Given this list of marker genes ADGRA3, THBS1 (thrombospondin 1, NCBI Gene Id 7057), ADRB2, PLTP, DNAJB4, TRIB3, HSPA6, JCHAIN, EIF4EBP1, GDF15, SLC3A2, CDS1, PTPRC (protein tyrosine phosphatase receptor type C), MMP16, RCAN2 (regulator of calcineurin 2), PPARGC1A, AAK1, TOX3, HSP90B1, MAF (MAF bZIP transcription factor), RPS6KA2, CTH, DNAJC15, MAFF, RRM2, EPB41L2, CLGN, GOT1, SLC47A1, PPP1R15A, HSPA1B, IDH1, TPP1, CRELD2, RGS16, ENPP2, FAM149A, NIBAN1, IFRD1, DNAJB1, LAPTM5, ATF3, HGF, HBB, BAG3, CBS, SHMT2, PPFIBP1, SLC6A15, CEBPB, E2F2, RFPL2 (ret finger protein like 2), P2RX5, MARS1, MYC, RPS19, PLEKHA8P1, CA2, USH2A (NCBI Gene Id 7399), CCPG1, MZF1, DNAJB9, OSGIN1, AMY1A (amylase alpha 1A), NEAT1, CEACAM1 (NCBI Gene Id 634), SERPINH1, CLK1, SLC5A3 (NCBI Gene Id 6526), SLCO4C1, MIA2, PSAT1, ATF4, OLR1, WARS1, CRBN, ADCYAP1, TXNDC5, DDIT4, SEC24D, CHAC1, UFM1, PKD1, INHBE, DDIT3, SLC1A4, HBG1, ASNS, STK39, PHGDH, MAP1B, F2RL1, SYT11, SLC7A11, HMOX1, HSPA1A, TIMM44, DDAH1, TSHR, CATSPER2, TNFRSF17 (NCBI Gene Id 608), HSPH1, LSAMP, PGM3, HSPA13, LRP2BP, PLG, here is a description of the gene set: studied in species Homo sapiens Genes down-regulated in at least one of three multiple myeloma (MM) cell lines treated with the DNA hypomethylating agent decitabine (5-aza-2'-deoxycytidine). from publication Heller G, Schmidt WM, Ziegler B, Holzer S, Müllauer L, Bilban M, Zielinski CC, Drach J, Zöchbauer-Müller S (PMID 18172295) To identify epigenetically silenced cancer-related genes and to determine molecular effects of 5-aza-2'-deoxycytidine (Aza-dC) and/or trichostatin A (TSA) in multiple myeloma (MM), we analyzed global changes in gene expression profiles of three MM cell lines by microarray analysis. We identified up-regulation of several genes whose epigenetic silencing in MM is well known. However, much more importantly, we identified a large number of epigenetically inactivated cancer-related genes that are involved in various physiologic processes and whose epigenetic regulation in MM was unknown thus far. In addition, drug treatment of MM cell lines resulted in down-regulation of several MM proliferation-associated factors (i.e., MAF, CCND1/2, MYC, FGFR3, MMSET). Ten Aza-dC and/or TSA up-regulated genes (CPEB1, CD9, GJA1, BCL7c, GADD45G, AKAP12, TFPI2, CCNA1, SPARC, and BNIP3) were selected for methylation analysis in six MM cell lines, 24 samples from patients with monoclonal gammopathy of undetermined significance (MGUS), and 111 samples from patients with MM. Methylation frequencies of these genes ranged between 0% and 17% in MGUS samples and between 5% and 50% in MM samples. Interestingly, methylation of SPARC and BNIP3 was statistically significantly associated with a poor overall survival of MM patients (P = 0.003 and P = 0.017, respectively). Moreover, SPARC methylation was associated with loss of SPARC protein expression by immunostaining in a subset of MM patients. In conclusion, we identified new targets for aberrant methylation in monoclonal gammopathies, and our results suggest that DNA methyltransferase and histone deacetylase inhibition might play an important role in the future treatment of patients with MM. Human Gene Set: HELLER_SILENCED_BY_METHYLATION_DN